Given this list of marker genes Cyba, Flna, Selenop, Nsg2, Ctsw, Lsp1, Cd96, Nkg7, Cd8b1 (CD8 subunit beta 1), Id3, Scp2, Hspa1a, Gpr174, Emp3, Hcst, Klf3, Tspan32, Ramp1, Ms4a4b, Cd3g, Pou2f2, Lrrfip1 (NCBI Gene Id 98585), Nlrc3, Fam78a (NCBI Gene Id 241303), Ccdc88c, Cd28, Trbc2, Fos, Shisa5, Cotl1, Hspa1b, Ugcg, Crlf3, Chd3, Itpkb, Grap, Bin1, Ypel3, Tecr, Rgcc, S100a10, Mxd4, Hdac7, Coro1a, Tagln2, Pitpnc1, Smc4, Themis, Bin2, Ahnak, Myh9 (NCBI Gene Id 97972), Arl5c, Bcl11b (B cell leukemia/lymphoma 11B), Grap2, Dapl1, B4galnt1, Limd2, Ltb, Klrd1, Actn1, Add3, Tecpr1 (tectonin beta-propeller repeat containing 1), Sit1, Acp5, Epsti1, Rasgrp2, Cxcr3, Klf2, Foxp1, Lcp1, Tln1, Sh3kbp1, Sidt1, 9930111J21Rik2, Itgb7, Hsd11b1, Cd2, Pycard, Lck, Kif21b, Dnajc15, Calm1, S100a6, Clec2d, Cd52, Cd5, Trim59, Ankrd44, Cd48, Rhoh, Rasgrp1, Ms4a4c, Gm2a, Fyb1, Tbc1d10c, Spn, Arhgdib (Rho, GDP dissociation inhibitor beta), Lcn4, Rac2, Cd8a, Evl, Srpk2, Lgals1, Lbh, Zmiz1, Zyx, Adcy7, Cd27, Mgst2, Crip1, Timp2, Otulinl, Ptp4a3, Dap, Itga4, Macf1, Mbnl1 (NCBI Gene Id 56758), Septin1, Itgae, Ighm, Hvcn1, Myl6, Stk38, Tmsb10, Cd226, Ptprcap, Sh2d3c, Atp1b1, Xcl1, Stap1, Smpdl3a, Btg2, Rgs10 (NCBI Gene Id 67865), Septin6, Eomes, Tubb5, Uba52, Tent5a, Bcl9l, Fxyd5, Sh3bgrl3, Adgre5, Actn2, Thy1, Slco3a1, Cd37, Tdrp, Klf6, here is a description of the gene set: Genes negatively differentially expressed in cell type: CD8+ T cell upon treatment with cytokine: IL-1α in mouse lymph nodes in vivo. from publication Cui A, Huang T, Li S, Ma A, Pérez JL, Sander C, Keskin DB, Wu CJ, Fraenkel E, Hacohen N (PMID 38057668) Mouse Gene Set: CUI_T_CELL_CD8_IL1A_RESPONSE_DN Cytokines mediate cell-cell communication in the immune system and represent important therapeutic targets. A myriad of studies have highlighted their central role in immune function, yet we lack a global view of the cellular responses of each immune cell type to each cytokine. To address this gap, the authors created the Immune Dictionary, a compendium of single-cell transcriptomic profiles of more than 17 immune cell types in response to each of 86 cytokines (>1,400 cytokine-cell type combinations) in mouse lymph nodes in vivo. A cytokine-centric view of the dictionary revealed that most cytokines induce highly cell-type-specific responses. For example, the inflammatory cytokine interleukin-1β induces distinct gene programmes in almost every cell type. A cell-type-centric view of the dictionary identified more than 66 cytokine-driven cellular polarization states across immune cell types, including previously uncharacterized states such as an interleukin-18-induced polyfunctional natural killer cell state. studied in species Mus musculus